The following is a description of a gene set: Genes predicted to be targets of miRBase v22 microRNA mmu_miR_12195_3p in miRDB v6.0 with MirTarget v4 prediction scores > 80 (high confidence targets). Mouse Gene Set: MIR_12195_3P from publication Chen Y, Wang X (PMID 31504780) species: Mus musculus, and this is the list of marker genes: Ptger2, Ncbp1, Zfp740, Nup50, Wdr43, Hsbp1 (heat shock factor binding protein 1), Hoxb6 (homeobox B6), Rcor3, Serinc5, Zfx, Ap3m2, Pigc, Pcdha9, Brdt, Hira, Pcdha5 (NCBI Gene Id 12941), Agpat1, Pafah1b1, Amot, Dicer1, Cblb, Usf3, Rb1, Igf1, Dusp10, Ammecr1l, Ube2v2, Col11a1, Sash1, Gfra2, Zfp622, Bach1, Pcdha10, Crebrf, Atp2b1, Flrt2, Slk, Pcdha1, Inpp5d, Vgll1, Eny2, Phtf2, Pcp4l1, Selenot, Fzd3, Mlxip, Pcdha4, Pcdha7, Sp1, Plcl1, Ckap4, Cep164, Rsbn1 (NCBI Gene Id 229675), Trpc1, Pcdhac1, Zfp131, Elavl4, Kctd18, Pcdha2, Pcdha3 (protocadherin alpha 3), Raph1, Pcdha11, Hmgb1, Grik3, Pcdhac2, Wee1, Pcdha8, Rnf168, Heca, Ermn, Arf6, Kif1c, Set, Cep350, Prkg1, Nav2, Otof, Csmd1, Pcdha12, Dnajc12, Rgmb, Pcdha6, Mef2c, C2cd2, Fign, Ddx3x, Rap2c, Hps3, Noct, Jade3, Cacnb2, Reln, Orc3